The following is a description of a gene set: studied in species Mus musculus The cell cycle process in which sister chromatids are organized and then physically separated and apportioned to two or more sets. Mouse Gene Set: GOBP_SISTER_CHROMATID_SEGREGATION, and this is the list of marker genes: Kat5, Dpf1, Drg1, Cdca8 (cell division cycle associated 8), Clasp2, Ccnb1-ps, Chmp3, Zwilch, Katnb1, Vps4b, Ripor2, Pbrm1, Ik, Chmp1a, Arid2, Hnrnpu, Mos, Xrcc3, Ndc80, Mybl2, Smc2, Spc25, Stag1, Anapc1, Birc5, Pinx1, Map9, Abraxas1, Kntc1, Smarca2, Smarca5, Bub3, Wrap73, Prpf4b, Dpf2, Cdc23, Dync1li1, Kif22, Kifc5b, Ccdc66, Nuf2, Snhg15, Ppp2r1a, Rad21, Bccip, Gen1, Stag2, Ncapg2, Cdt1, Kif11, Apc, Smarce1, Golga2, Anapc4 (anaphase promoting complex subunit 4), Klhl22, Prap1, Chmp4c, Phf13, Ska1, Ofd1, Mad2l1bp, Nek2, Cenpk, Cit, Kif4, Pibf1, Chmp1b2, Smarcd3, Spc24, Ino80, Spag5, Mad2l1, Kif18a, Atf6b, Poldip2, Cenpe, Psmg2, Cdc6, Aurkb, Espl1, Numa1, Chek2, Actb, Baz1b, Plk1, Fbxo5, Kif23, Tubg1, Ska3, Arhgef10, Cdc16 (NCBI Gene Id 72610), Ccdc61, Chmp2b, Anapc7, Tpr, Prc1, Usp44, Spice1 (spindle and centriole associated protein 1), Knl1, Nup62, Dctn2, Tex14, Rangrf, Hspa1b, Chmp7, Cltc, Smarca4, Nek6, Chmp4b, Arid1a, Psrc1 (NCBI Gene Id 99778), Top2b, Ska2, Smc4, Kif18b, Smarcb1, Eml3, Spdl1, Anapc5, Bub1b, Vps4a (NCBI Gene Id 78220), Wapl, Ncapd3, Aaas (achalasia, adrenocortical insufficiency, alacrimia), Kat2b, Nsmce2, Chmp5, Uhrf1 (NCBI Gene Id 18140), Bcl7c, Akap8, Chmp2a, Bcl7b, Mis12, Smarcd2, Kif15, Kif2c, Flna, Anapc15-ps, Zfp207, Tpx2, Top2a, Kpnb1, Riok2, Lsm14a, Tacc3, Ccnb1, Chfr (checkpoint with forkhead and ring finger domains), Kifc1, Bcl7a, Brd7, Anapc15, Seh1l, Cdca5, Cdc20, Ncaph2, Hspa1a, Ccsap, Anapc2, Smc1a, Cdk5rap2 (CDK5 regulatory subunit associated protein 2), Smarcc2, Mapre1, Bub1, Sirt1, Rb1, Racgap1, Nipbl, Actl6b, Ube2c, Rhoa, Zwint, Dusp1, Arhgap33os, Nsl1, Smarcd1, Rrs1, Map10, Rab11a, Ncapd2, Nudc, Phf10, Knstrn, Incenp, Atm, Khdc3, Eml4, Pcid2, Anapc11, Trip13, Clasp1, Mzt1, Lcmt1, Mad1l1, Tubg2, Rmi2, Misp, Rcc1, Haspin, Mapk15, Prickle1, Dpf3, Ankrd53, Kif3b, Abraxas2, Actl6a, Lats1, Ttk, Cenpi (NCBI Gene Id 245603), Dis3l2 (DIS3 like 3'-5' exoribonuclease 2), Kif14, Ncapg, Nusap1, Smc3, Ube2u, Cep192, Cul3, Ncaph, Cdc27, Becn1, Cep97, Zw10, Champ1, Chmp1b, Cenpc1, Ran, Hecw2, Cdk1, Kif2a, Smarcc1, Chmp6, Akap8l